The following is a description of a gene set: Any process that activates, maintains or increases the rate of pinocytosis. Pinocytosis is the process in which cells take in liquid material from their external environment; literally 'cell drinking'. Liquid is enclosed in vesicles, formed by invagination of the plasma membrane. These vesicles then move into the cell and pass their contents to endosomes. Human Gene Set: GOBP_POSITIVE_REGULATION_OF_PINOCYTOSIS studied in species Homo sapiens, and this is the list of marker genes: APPL1, APPL2, AXL, CLN3, PPT1, CDC42, ANKFY1